Given this list of marker genes UBE2S (ubiquitin conjugating enzyme E2 S), ANAPC5, UBE2C, UBE2D1, ANAPC2, CDC26, ANAPC1, CDC20, CDC23, ANAPC15, BUB1B, ANAPC4, ANAPC11, CDC27, MAD2L1, ANAPC10, ANAPC16, UBE2E1, ANAPC7, BUB3, CDC16, here is a description of the gene set: The target of the mitotic checkpoint is the Anaphase Promoting Complex/Cyclosome (APC/C) an E3 ubiquitin ligase that targets proteins whose destruction is essential for mitotic exit. Currently, there are two proposed mechanism by which inhibition of the APC/C is achieved. These mechanisms differ depending on the mechanism of signal transduction. The APC/C may be inhibited directly by association with the Mitotic Checkpoint Complex (MCC) or through the sequestration of its activator, Cdc20. studied in species Homo sapiens Reactome Pathway: Inhibition of the proteolytic activity of APC/C required for the onset of anaphase by mitotic spindle checkpoint components part of: Mitotic Spindle Checkpoint; Regulation of APC/C activators between G1/S and early anaphase